The following is a description of a gene set: Mouse Gene Set: MIR_7023_3P from publication Chen Y, Wang X (PMID 31504780) Genes predicted to be targets of miRBase v22 microRNA mmu_miR_7023_3p in miRDB v6.0 with MirTarget v4 prediction scores > 80 (high confidence targets). studied in species Mus musculus, and this is the list of marker genes: Rap2a, Arrdc3, Hic2, Eva1a, Recql5, Wdr26, Col24a1, Slc7a1 (solute carrier family 7 (cationic amino acid transporter, y+ system), member 1), Tmem170b, Notch1, Hif1an, Bltp3a, Samd4b, Nrbf2, Ppp1r3d, Zfp710, Brinp2, Chdh, St6gal2, Trappc9, Pakap, Cp, Epha5, Zc3h4, Cstf2, Pdcd1lg2, Hoxa1, Dhfr, BC107364, Zfp128, Tango6, Itsn1, Fgf5, Wdr1, Dock11, Nhsl2, Kcns3, Ifih1, Adi1, Ccdc22, Tmod2, Nyap2, Nudt9, Tomm20, Spsb4, Prrg3, Syn3, Heatr6, Map3k9, Adarb2 (adenosine deaminase, RNA-specific, B2), Septin3, Tbxas1, Tmem161b, Szrd1, Plcd3, Gas2l3, Kl, Grsf1, Tbc1d22b, Elavl3